Given this list of marker genes RAP1A, TLN1, GRB2, VWF, FGG, ITGA2B, FN1, FGA (fibrinogen alpha chain, NCBI Gene Id 2243), SRC, FGB, SOS1, APBB1IP, RAP1B, ITGB3, PTK2, here is a description of the gene set: studied in species Homo sapiens Human Gene Set: REACTOME_GRB2_SOS_PROVIDES_LINKAGE_TO_MAPK_SIGNALING_FOR_INTEGRINS GRB2:SOS provides linkage to MAPK signaling for Integrins